The following is a description of a gene set: studied in species Mus musculus Mouse Gene Set: GOBP_NUCLEOTIDE_EXCISION_REPAIR_DNA_GAP_FILLING Repair of the gap in the DNA helix by DNA polymerase and DNA ligase after the portion of the strand containing the lesion has been removed by pyrimidine-dimer repair enzymes., and this is the list of marker genes: Pold1, Pole, Lig4, Polk, Pold3